The following is a description of a gene set: NGF-stimulated transcription Mouse Gene Set: REACTOME_NGF_STIMULATED_TRANSCRIPTION species: Mus musculus, and this is the list of marker genes: Creb1, Nab2, Egr2, Sgk1, Srf, Chd4